The following is a description of a gene set: Genes down-regulated in CD4 T cells treated with TGF beta and IL6: STAT3 knockout versus wildtype. from publication Durant L, Watford WT, Ramos HL, Laurence A, Vahedi G, Wei L, Takahashi H, Sun HW, Kanno Y, Powrie F, O'Shea JJ (PMID 20493732) STAT3, an essential transcription factor with pleiotropic functions, plays critical roles in the pathogenesis of autoimmunity. Despite recent data linking STAT3 with inflammatory bowel disease, exactly how it contributes to chronic intestinal inflammation is not known. Using a T cell transfer model of colitis we found that STAT3 expression in T cells was essential for the induction of both colitis and systemic inflammation. STAT3 was critical in modulating the balance of T helper 17 (Th17) and regulatory T (Treg) cells, as well as in promoting CD4+ T cell proliferation. We used chromatin immunoprecipitation and massive parallel sequencing (ChIP-Seq) to define the genome-wide targets of STAT3 in CD4+ T cells. We found that STAT3 bound to multiple genes involved in Th17 cell differentiation, cell activation, proliferation and survival, regulating both expression and epigenetic modifications. Thus, STAT3 orchestrates multiple critical aspects of T cell function in inflammation and homeostasis. studied in species Homo sapiens Human Gene Set: GSE21670_STAT3_KO_VS_WT_CD4_TCELL_TGFB_IL6_TREATED_DN, and this is the list of marker genes: NFE2L2, MSN, CLEC4E, SDCBP, NEK7, PDGFC, PARP4, PTPRJ, MCTP1, NMT2, ITM2B, PMFBP1, PLBD1, PSAP, UTRN, DAPK1, IGFLR1, CD27, APBB1IP, SLC17A5, RASSF3, CREG1, CITED2, TXNIP (NCBI Gene Id 10628), LYZ, SIGLEC1, GCNT4, LRRK2, TMBIM1, CA11, ACP3, SLC12A6, TIMD4, AVPI1, SLC37A2, TPP1, DGKZ, RCSD1, MDS2, NPL, CTDSP2, ZFYVE16, FAM78A, STK38, AHNAK, CD5, YPEL4, MRAS, RTN1, RRM2B, TXLNB (NCBI Gene Id 353506), ADAMDEC1, PDE7A, CD52, MARCHF1, FAM111A, ARRB1, MITF, FGL2, LFNG, CPED1, RAP2B, CCPG1, ME1, ITGA5, NAB2 (NGFI-A binding protein 2), TRAV8-3, GCLC, CLEC6A, PAQR8, SERPING1, ACP5, APOBEC3A, VSIR, ARRB2, MNDA, RCBTB2, RGS10 (regulator of G protein signaling 10), SLC44A1, TMEM63A, SPTBN1, RHBDD2, XCR1, FMNL1, SORL1, SLC36A1, WNT7A, ALDH1A1, TTYH2, ASRGL1, CAMSAP2, ANXA11, AQP3, GPNMB, RNASE1, ATP10D, MYADM, GLG1, ITGB7 (NCBI Gene Id 3695), CA2, ZNF831, IQSEC1, LRP1, IL16, NCEH1, SLC1A3, ID3, TPP2, ARHGAP9, ATP6AP2, TBL1X, CTSB, DPEP2, ADAM28, CREBL2, KIAA0930, ZYX, ZMIZ1, TGFBI, IPCEF1, CXCL10, MSR1, C5, PRCP, PDK4, SLC16A5, RGS2, SPARC, PLD3, TLR4, CPVL, RIPOR2, SORBS3, CD4, RASGRP2, SUN2, MPP1, ELF1, BNIP3L, CTSS, DHRS9, SLAMF7, RGCC, GNS, CD40LG, TNFRSF1A, EPHX1 (NCBI Gene Id 2052), ASAH1, RNASE6, CEMIP2, SIRPG, SEPTIN9, ITGB2, CD180, GABBR1 (gamma-aminobutyric acid type B receptor subunit 1), GPAT3 (NCBI Gene Id 84803), CLEC2D, PIP4P2, SMIM14, DUSP10 (NCBI Gene Id 11221), WIPF1, MANBA, NCAM1, TLK1, CCDC88A, TEP1, GASK1B, ADA2, ZFP36L2, TMT1A, ADGRE5 (adhesion G protein-coupled receptor E5), ESYT1, DIAPH1, GRN, LAIR1, CLEC4D, LBH, ARRDC2, FUCA1, KLHL3 (NCBI Gene Id 26249), DSC1, SMC4, CD9, CCM2, TSC22D3, SIRPB2, GPX4, IL36A, CYBRD1, SSBP2, STAB1, BMPR2, ACTN1, TIMP2, LITAF, ARHGAP21, IL13RA1, ANXA4, MADD, NLRP3